Given this list of marker genes BAX, HOXA5, GATA3, IQGAP3, PYGO2, DEAF1, ZNF703, RREB1, KDM5B, PHB2, RTN4, CDKN2A, ROBO1, CCND1 (NCBI Gene Id 893), BRCA2, GPX1, here is a description of the gene set: Human Gene Set: GOBP_REGULATION_OF_MAMMARY_GLAND_EPITHELIAL_CELL_PROLIFERATION Any process that modulates the frequency, rate or extent of mammary gland epithelial cell proliferation. species: Homo sapiens